The following is a description of a gene set: Any process that activates or increases the frequency, rate or extent of MAP kinase activity. studied in species Homo sapiens Human Gene Set: GOBP_POSITIVE_REGULATION_OF_MAP_KINASE_ACTIVITY, and this is the list of marker genes: TPD52L1, DRD4, FLT1, DIRAS1, ERN1, MAP3K11, TRAF6, MAP4K2, TAOK3, ELANE, PDCD10, TRAF2, FGF1, DIRAS2, TENM1, RASGRP1, MST1R, MAP3K4, PIK3CG, EZH2, CRIPTO, ERBB2 (erb-b2 receptor tyrosine kinase 2), MAP3K5, MAP3K10, SASH1, PIK3R6, NEK10, ARHGEF5, S100A12, TLR6, PIK3R5, FLT3, FGF18, MAP3K7, TNF, FGFR1, PDGFRB (NCBI Gene Id 5159), PDGFB, FGF2, PTPN1